The following is a description of a gene set: Human Gene Set: MYCMAX_B Genes having at least one occurrence of the motif GCCAYGYGSN in the regions spanning 4 kb centered on their transcription starting sites. This matches the MYC, MAX transcription factor binding site V$MYCMAX_B (v7.4 TRANSFAC). species: Homo sapiens, and this is the list of marker genes: CCER1, WEE1, IPO7, BCL11B, XRN2, OR2L13, H1-10, KPNB1 (NCBI Gene Id 3837), GFI1, SDHB, RPS6KA3, HNRNPR, PITPNA, DIAPH1, KLHL35, UBXN10, ELAVL3, RIMKLA, NKX2-8, CRMP1, HNRNPDL, NSUN2, PCBP4, SCRT2, C1orf21 (chromosome 1 open reading frame 21), ARL3, HOXB9, GTF2A1, SUN2, MMP23B, KICS2, ACY1, ALDH1A2, TCOF1, ABTB2, ZNRF2, HENMT1, CXCL14, HOXC5, AJUBA, KANSL3, ACVR2A, AMMECR1L, TRIB1, NTN3, CELF4, CCND1, KCNH2, IRX2, TAOK2, PIGW, SLC1A1, CALM2, TSEN2, TGIF2 (NCBI Gene Id 60436), ETF1, RND3, EXOSC5, CDK16, PTCHD4, SLC25A33, G6PC3, RORC, ANAPC10, PLCD1, KDM3A, NEUROD1, NR2E1, PDIA2, SYT7, KCNH4, TOX2, NUTF2, TMEM59L, EIF5A, PPARGC1B, TNPO2, GRIN2B, HS3ST3B1, BCKDHA, TFAP2C, MMP23A, KLF13, IRF2BPL, PTK7, FCHSD2, MYO19, CYP2D6, ZFP1, SEC61A1, WNT1, TBX2, SDK1, SCML2, JPT1, SNAP25, LRFN5, PHF7, TSC22D4, SOX12, SOX4, SYT12, PER1, SNRNP70 (NCBI Gene Id 6625), NSF, HOXA9, TMEM132E, CPNE5, TAF11, RANBP1, HPCA, PITX3, KIT, VEGFA, TRPC4AP, NDUFS1 (NCBI Gene Id 55372), IRX2-DT, FOXA2, NSMF, PTOV1, DAZL, CRK, RPS19, TMEM248, PCYT2, TMEM43, ILF3-DT, STAG2, RTBDN, RCL1, CATSPER2, FGF14, PLXNC1, BZW2, KLF10, TMEM132E-DT, NPM1, SPAG9, SMAD7, CTIF, SALL1, TSHZ2, HMGA1, ARF6, EWSR1, EEF1B2, DLL4, BHLHE41, PES1, NR1D1, CEBPA-DT, PIH1D2, YTHDF2, SPOP, RBM24, PGRMC2, IVNS1ABP, SERPINF1, ASCL2, SPG21, ATPSCKMT, STMN1, HOXC4, SLC25A5, ZDHHC5, SERBP1, LIPT2-AS1, RAPGEF6, ISL1, TGIF1, ZNF362, WWC1, NADK2, PIP4K2B, DERL3, SNX5, DNAJC11, AK3, APLN, CALM3, EPHA2, CREBZF, RBBP7, CAMKV, PDP2, PICALM, PTF1A, ENPP6, FXR2, ATOSB, SIX5, CRABP2, XYLT2, CEP95, VAPA, MEX3B, SUGP2, RNF146, MARCKSL1, ZDHHC14, RAI14, GIT1, ZNF771, PAIP2, ID1, TXLNG, INSM1, PTMA, ZNF574, DAZAP1, UBE2S, ZNF367, SRF, SOCS3, ASCL1, PABPC1, UBE2D3, HPCAL4, NAT8L, L1CAM, ALOXE3, MGME1, MMP11, SEMA7A, ANKZF1, PAX2, TRMT2A, HNRNPD, CNBP, EPS8, EBAG9, ANKMY2, SHKBP1 (NCBI Gene Id 92799), TFAP4, NFATC4, AHCTF1, PARP6, BAP1, EIF3B, LAMB1, DYM, ATG9A, CA10 (carbonic anhydrase 10), NCL, ZFP36L1, HSF4, PRKAG2, PFN1, NEUROG3, EGR3, MICAL2, STARD13, PDGFB, ANKS1A, CCT5, FAM117B, SIX1, NKAPD1, ST3GAL2, DBP, RNF125, CEBPA (NCBI Gene Id 1050), OSBPL10, DLGAP4, PPP1R9B, ZNF800, ILF3, ELOVL6, ABCE1, TRIM8, VAX1, LRP8